Given this list of marker genes NPTN, FXR1, SHANK3, NEURL1, FMR1, FXR2, EPHB2 (EPH receptor B2), GRM5 (glutamate metabotropic receptor 5), KIT, here is a description of the gene set: A process that increases long-term neuronal synaptic plasticity, the ability of neuronal synapses to change long-term as circumstances require. Long-term neuronal synaptic plasticity generally involves increase or decrease in actual synapse numbers. species: Homo sapiens Human Gene Set: GOBP_POSITIVE_REGULATION_OF_LONG_TERM_NEURONAL_SYNAPTIC_PLASTICITY